The following is a description of a gene set: Mouse Gene Set: GOBP_REGULATION_OF_UBIQUITIN_PROTEIN_TRANSFERASE_ACTIVITY species: Mus musculus Any process that modulates the frequency, rate or extent of ubiquitin transferase activity., and this is the list of marker genes: Mad2l2, Bag2, Psen2, Arrdc3, Rps7, Arrdc4, Abl1, Mad2l1, Ube2srt, Ube2s (NCBI Gene Id 77891), Btrc, Ube2l3, Bag5, Park7, Cdc20, Trib1, Psen1, Trib3, Smad7, Rps2, Rpl5, Plk1, Fzr1, Skp1, Rpl11, Fem1b, Stub1, Fbxo5 (F-box protein 5), Pten, Limk1, Usp44, Cdc14b, Dnm1l, Fbxw7, Fem1al, Rpl23, Topors, Fem1a, Cdkn2a, Trib2, Dtx3l, Epm2a, Mastl, Bmi1 (Bmi1 polycomb ring finger oncogene)